The following is a description of a gene set: Reactions triggered in response to the presence of another organism that act to protect the cell or organism from damage caused by that organism. studied in species Mus musculus Mouse Gene Set: GOBP_DEFENSE_RESPONSE_TO_OTHER_ORGANISM, and this is the list of marker genes: Ccl19-ps3, Naip6, Tifa, Nr1d1, Cd226, Siglecg, Cxcl11, Vip, Wfdc13, Aqp1, Ccl17, Pfpl, Clpb, Aicda (activation-induced cytidine deaminase), Cfh, Klrg1, Ptprc, Klrb1 (killer cell lectin-like receptor subfamily B member 1), Npy, Atl3, Gbp8, Agbl5, Bnip3, Fv1, Neurl3, Tlr1, Usp50, Oas3, Cdc42, Batf, Defb40, C8g, Hmgb1, Lyzl6, Btk, Sprr2a1, Zdhhc1, Trim3, Il10rb, Nt5c2, Jak3, Ifnab, Fcer1g, Tarbp2, Gzmc, Zfp683, Lamp1, Epha2, Pik3cd, Samhd1 (NCBI Gene Id 56045), Epg5, Bpifa1, Rnf31 (ring finger protein 31), Defa25, Ap3b1, Rab1a, Cd207, Casp4, Wfdc2, Nop53, Sin3a, Ifi213, Serpinb1a, Myo1f, Calm3, Nek7, Gpatch3, Defb39, Casp1, Defb30, Irgm1, Slfn9, Il23a, Reg2, Tkfc, Arf6, Raet1e, F2, Lrrc15, Trim31, D1Pas1, Mptx2, Il12a, Adamts4, Tnfrsf14, Tgfb1, Ripk3, Tax1bp1, Cdc42ep2, Trim43a, Rab27a, Cst9, Ifitm3, Prkdc, Jak2, Arid5a, Ubd, Ifna7, Stx11, Traf3ip2, Defb35, Seh1l, Bpifa2, Fcna, Tmem106a, Crp, Ch25h, 9930111J21Rik1, Usp17le, Galp, Defa20, Il7r, Erbin, Trim11, Trim43c, Ass1, Trim55, Gfi1, Calhm6, Nmb (NCBI Gene Id 68039), Nlrp9c, Trex1, Defb46 (NCBI Gene Id 574081), Fbxo9, Fpr-rs4, Cxcl5, Hmgb2, Cd300e, Oasl1, Zdhhc12, Klre1, Rab7b (NCBI Gene Id 319567), Ear2, Slamf7, Wipi2, Fosl2, Pspc1, Myd88, Cd160, Clec4e, Apoe, Hamp2, Pglyrp2, Wfdc5, Hck, Ccl22, Foxp3, Rnf135, Rab12, Gapdhrt, Nfkb1, C1ra, Klrb1b, Ccl2, Defa40, Eif2ak4, Arhgef2, Cadm1, Il17f, Dus2, Nectin4, Fbxl2, Ifngr1, Trim30a, Znrf4, Il27, Tnip1, Lrrc19, Il1rl2, Defb42, Dmbt1, Gbp9, Ccl1, Defa35 (defensin, alpha, 35), Hras, Mmp3, Ncf1, Exosc4, Defa34, Akap8, Adm (adrenomedullin), Apobec3, Zbtb1, Trim60, Rnaset2b, Defa28, Snx3, Wdfy1, Rnf185, Chmp3, Ninj1, Cybc1 (NCBI Gene Id 217370), Il1rap, Prkra, Ppp6c, Pten, C1qbp, Mif, Raet1d, Tspan32, Pla2g6, Ifit1, Ccl19-ps4, Tlr12, Nlrp6, Ube2w, Reg1, Sting1, Clec4a4, Defa37, Hvcn1, Ppt1, Hpx, Defb50, Klk5, Mark4, Lep, Il21 (interleukin 21), Calm1, Unc93b1, Pglyrp4, Tlr2, Lyz1 (lysozyme 1), Rsad2, Gm13276, Syncrip, C1qc, C1rl, Ifna16, Ccdc88b (coiled-coil domain containing 88B), Itgax, H2-T23, Zdhhc5, Kcnk13, Il36g, Pld3, Lgals4, Trim65, Gsdma2 (NCBI Gene Id 78322), Ccl5, Slamf1, Prdx1, Ripk2, Itln1, Slamf6, Rb1cc1, Il4, Tnfaip8l2, Defb18, Ighm, Trim21, Cd74, Ceacam1, Pum1, Oas1b, Pqbp1, Wfdc9 (WAP four-disulfide core domain 9), Il17rc, Clec4n, C1qa, Gm12185, Spag11a, Masp2 (NCBI Gene Id 17175), Msrb1, Ifnb1, Ptpn2, Fpr-rs6, Tmem33, Irf2, Tnip3, Pvr, Ins2, Trim25, Il17a, Serpinb9f, Wfdc21, Atad3a, Cd300lf, Ccl6, Gm5849, Defb15, Polr3k, Phb2, Ifne, Smarca5, Defb10, Adam15, Trim39, Cr2, Plscr1, Ddx17, Shmt2, F830016B08Rik, Lats2, Myo1c, Emilin1, Slc15a3 (solute carrier family 15, member 3), Rnf115, Il18rap, Calcoco2, A2m, S100a14, Mov10, Ddx41, Lgals3, Apcs, Wnt5a, Ppl, Usp38, Trim34b, Nr1h3, Nlrx1, Plpp6, Plac8, Trim30b, Trim30d, Pmaip1, Pja2, Axl, Trem3, Pla2g10, Ifnlr1, Ccl12, Xrcc5, Defb8, Tnfsf8, C1qb, Trim7 (NCBI Gene Id 94089), Acp5 (acid phosphatase 5, tartrate resistant), Map4k2, Mmp7, Cd47, Ifi207, Syt11, Trem2, Drd2, Akap1, Dhx36, Sirpa, Daxx, Gbp5, Arl8b, Rab43, Fgr, Dtx3l, Arg2, Bpifa5 (NCBI Gene Id 72437), Gm13277, Cybb, Mfhas1, Gramd4, Klrh1, Itch, Defa2, Gm13275, Tmem120a, Pum2, Ifna5, Il36rn (NCBI Gene Id 98939), Armc5, Lta, Rpl13a, Shfl, Defa39, Defa26, Defb19, Casp8, Krt6a, Ly86, Lyar, Defb13, Nmi, Smim30, Ccl21d, Mapkapk2, Ighg2b, Ilrun, Ifitm6, Wfdc15a, Trim8, Nono, Nfkbiz (nuclear factor of kappa light polypeptide gene enhancer in B cells inhibitor, zeta), Cebpg, Pcbp2, Lalba, Rnaset2a, Serpine1, Was, Slc30a8, Cep63, C4b, Rnase12, Polr3c, Dnaja3, Ifi203-ps, Casp6, Kng2, Cfhr4, Klrc1, Tab2, Irak2, Gimap5, Rpsa, Ppm1b, Bspry, Lrrc14, Ppp2ca, Ifitm2, Oas1a, Ly96, Usp29, Mre11a, Nod2, Ffar2, Tlr4, Zmpste24, C9, Mpo, Vav1, Zmynd11, Defa17, Sqstm1, Banf1, Trem1, Oas1f, Gimap3, Dhx9, Rnasel, Ilf3, Emilin2, Dicer1, Krt1, Nlrc4, Hamp, Ifi208, Il22ra1, Letmd1, Chga, Ccl28, Gm15441, Rnase2a, Wfdc17, Esr1, Defa3 (defensin, alpha, 3), Cd244a, Nlrp4a, Mapkbp1, Ccl21b, Defb47 (NCBI Gene Id 654465), Colec11, Klk7, Stat5a, Zdhhc11, Rnf216, Gm13272, H2bc21, Fga, Vamp8, Trim50, Peli3, Reg3g, Defa38, Cldn1, Kcnj8, Srebf1, Ptpn6, Cd37, Serping1, Ppbp, Ulbp1, Irf7, Ifna11, Tlr6, Kif16b (kinesin family member 16B), Nfkbia, Fasl, Sp110, Rnf39, Ifi209, Vsig4, Aurkb, Gpr146, Slc26a6, Nlrp9b, U90926, Defa29, Smpdl3a, Foxp1, Elmod2, Ssc5d, Smpd1, Pla2g5, Klrd1, Traf3ip1, Ifit1bl2, Tgtp2, Klri1 (killer cell lectin-like receptor family I member 1), Sertad3 (SERTA domain containing 3), Vnn1, Ticam2, Defb3 (NCBI Gene Id 27358), Gch1, Sfn, Cav1, Sarm1, G3bp2, Ifna15, Nectin2, Gimap6, Prdm1, Defa24, Htra1, Camk2a, Ndufs4, Slfn8, Kat5, Atat1, Dhx58, Parp9, Ccl3, Hexim1, Defb43, Naglu, H2-M3, Ulbp3, Colec12 (NCBI Gene Id 225157), Irak1, Ipo7, Rnf26rt (NCBI Gene Id 669536), Plekhm2, Cd84, Il33, Gm12250, Slamf8, Defa30, Defb7, Sh2d1a, Ciita, Elp6, Aars2, Rftn1, Eprs1, Ear14, Ticam1, Znrf1, Rnf125, Gzmn, Fgl2, Ccl25, Il36a, Mx1, Il1b, Gzmb, Tnfaip8, Mr1, Muc19, Dpp4, Ccl7, Sh2d1b2, Marco, Ubqln1, Ang4, Ighe, Klrb1a, Klrb1c, Hp, Ywhaz, Cd36, Zdhhc4, Syk, Dcst1, Clnk, Lacc1, Ctsg, Ins1, Jagn1, Mbl2, Ncr1, Fpr-rs7, Trim30c, Defb21, Ifi35, Txk, Gm4841, Gata6, C3, Tmem45b, Ifit1bl1, Prkd1, Ppp1r14b (protein phosphatase 1, regulatory inhibitor subunit 14B), Klrc2 (killer cell lectin-like receptor subfamily C, member 2), Ccl26, Polr3g, Ang6, Csf1r, Trim61, Tyrobp, Fau, App, Sprr2a3, Fgb, Cd55b, Trim12a, Lrch4, Cd2, Trim72, Igha, Colec10, F2rl1 (NCBI Gene Id 14063), Gbp2, Ear1, Tnf, Cd55, Cxcl9, Phb1, Ifnk, Actg1, Defb33, Serpinb9c, Rasgrp1, Slc19a1, Fcgr1, Isg20, Marchf2, Morc3, Defb34, Mpeg1, Il6, Defb48 (defensin beta 48), Slamf9, Defb5, Tslp, Irak4, Kynu, Bpifb1, Rab2b, Trim40, C8b, Cxcl15 (C-X-C motif chemokine ligand 15), Il17ra, Ccr1, Ap1g1 (NCBI Gene Id 52301), Rps6kb1, Irf8 (NCBI Gene Id 15900), Wfdc15b, Ccl21e, Iigp1, Abcc1, Chid1, Cyp27b1, Rbm47, Traf4, Nlrp4b, Tollip, Tlr7, Rnf166, Krt16, Ly9, Cxcl16, Wap, Nagk, Cactin, Wfdc6a, Masp1, Ncbp1, Atg9a, Pf4, G3bp1, Ccdc134, Pde12, Trim14, Rnase4, Iigp1c, Ltf, Defb22, Src, Dao, Mx2, Il23r, Ifit3b, Sirt2, Ifna2, Fadd (NCBI Gene Id 14082), Mapk8, Ifi205, Il12rb1, Aif1, Trim15 (NCBI Gene Id 69097), Cebpb, Eif2ak2, Oas1g, Tirap, Pik3r1, Wrnip1, Nkg7, Cotl1, Klrb1f, Trim41, Defb20, Rtn4, Nlrc5, Dhx16, Gm13271, Ifnz, Nfkbil1, Ifi214, Muc5b, Cyba, Ccl9, Appl1, Chuk, Cfb, Zdhhc3, Hmgb3, Gm13283, H2-Q7, Dab2ip, Mill1, Reg3b, Cxcl1, Pglyrp3, Slc22a5, Wfdc16, Usp44, Pld4, Gapdhrt2, C8a, Clec4d, Mptx1, Bpifc (BPI fold containing family C), Stx4a, Pstpip1, Gigyf2, Mul1 (mitochondrial ubiquitin ligase activator of NFKB 1), Ncr3-ps, Cd14, Gsdmd, Tmf1, Otop1, Nlrp4f, Usp20, Stat1, Pml, Gapdh (NCBI Gene Id 407972), Cd300c2, Cd1d1, Ogt, Shc1, Ankrd17, Polr3e, Dusp10, Oas1e, Rad50, Nlrp3, Gm6040, Lypd8, Pim1, Usp14, Rela, Fcer2a, Oprk1, Defa42, Mmp12, Rigi, Ifitm7, Hyal2, Atg12, Rab14, Il4ra, Ddx21, Defb14, Cd96 (CD96 antigen), Rarres2, Rasgrp4, Star, Zg16, Cr1l, Cx3cr1, Gsdmc4, Usp15, Zbp1, Ythdf2, Polr3a (polymerase (RNA) III (DNA directed) polypeptide A), Defb1, Cd1d2, Hk1, Cxcl13, Bpi, Cxcl14, Inpp5d, Ubl7, Vps26b, Nppb, Edn1, Lag3, Trim62, Crtam, Clec4b2, Rnase10, Ufd1, Defb11, Brcc3dc, Xcl1, Zdhhc18, Cd177, Rbm14, Hrg, Ddx39a, Serinc5, Stxbp2, H60c, Bcl2, Polr3b, Spi1, Cx3cl1, Rbpj, Clec4a2, Enpp1, Adam8, Tusc2, Apoa4, Hspd1, Rnf144a, Gsn, Trf, Akt1, Becn1, Havcr2, Adamts5, Rnase1, Cyld, Nedd4, Nlrp1b, Il36b, Stx8, Serpinb9g, Wfdc3, Rpl30, Bcl10, C1s2, Slc46a2, Tlr3, Zcchc3, Endod1 (endonuclease domain containing 1), Fpr2, Ifnl2 (interferon lambda 2), Herc6, Rag2, Csf1, Fam3a, Trim12c, Trim10, Lyz2, Abcf3, Ccdc92, Ccl20, Trim56, Ccl24, Lyplal1, Abhd17a, Creb3, Ifi211, Bcl2l1, Ighg2c, Lrrfip2, Dapk1, C4bp, Ivl, Rnf34, Gbp6, Ifi203, Pdpk1, Brcc3, Trim54, Triml2, Tab1, Senp7, Gpr15lg, Sharpin, Camp, Ear10, Mmrn2, Stab2, Cstdc2, Gsdmc3, Rpl39, AY761185, Mid2, Lyn, Xiap, Mlkl, Cd300c, Gps2, Defa22, Oasl2, Wfdc11, Ptx3, Naip1, Ikbkg, Tspan6, Ighg1, Rnase13, Capg, Setd2, Apol11a, Trim34a, Nt5c3, Gpam, Reg3a, Ifna12, Cd4, Lyz3, Flicr, Vamp4, Usp18, Nras, Trim58, Tril (NCBI Gene Id 66873), Mettl3, Pla2g2a, Skp2, Ddx56, H60b, Actr2 (actin related protein 2), Cpt1a, Ang (angiogenin, ribonuclease, RNase A family, 5), Lyst, Sftpd (surfactant associated protein D, NCBI Gene Id 20390), Il10, Inava, Gsdma3, Ang2, Ighg3, Lrsam1, Tasl, Defb9, Matr3, C1s1, Appl2, Map3k5, Trim63, Trim35, Drosha, Garin5a, Wfdc18, Traf3ip3, Ube2n, Hdac4, Tbkbp1, Vim, Rel, Klrc3, Ifng, Eppin, Prkcd, Epx, Tnfsf4, Trim26, Nlrp4c, Tifab, Cfi, Rab11fip5, Ifnar1, Adamts13, Ttll12, Defa21, Traf6, Pgc, Prf1, S100a9, Defb41, Nlrp1a, Ppp1r11, Ifna1, Serpinb9d, Cd300a, Gpr108, Aqp4, Nr1h4, Ifit3, Ywhae, Tnfaip3 (NCBI Gene Id 21929), Cd274, Peli1, Leap2 (NCBI Gene Id 259301), Nod1, Sh2d1b1, Defb36, Bst2, Evpl, Cptp, Lcn10, Irf1, Lyg2, Uba7, Irf3, Gsdma, H2-K1, Lcn2, Akirin2, Fosl1 (NCBI Gene Id 14283), Padi4, Ifna9, Sp100, Cdc42ep4, Optn, Inhca, Atg5, Il34, Defb12, Rps6ka3, Rnase2b, Usp27x, Cgas, Clec12b, Rnf19b, Susd4, Cnot7, Rnf213, Scd1, Oas1d, Ttc4, Notch2, C5ar1, Bnip3l-ps, Cxadr, Slc9a9, Cxcl10, Tagap, Wfdc10, Casp7, Serpinb9, Slc22a21, Ifitm1, Eif4e2, Nlrc3, Lrp8, Defb25, Trim5, Ube2k, Ccl27al, Map3k7, Dhx33, Ifnar2, Rab20, Ecsit, Pcyox1l, Gper1, Adar, Rnase11, Nqo1, Myo18a, Cdc37, Tap1, Nck1, Cfp, Wfdc12, Defa41, Defb37, Hcfc2, Jchain, Irf4, Trim68, Ddit4, Nfe2l2, Ifngr2, Igtp, Mcoln2, Grn, Ereg, Tmem126a, Stxbp4, Ythdf3, Gbp7, Fcnb, Fgg, Hsp90aa1, Ankhd1, Sec14l1, Serpinb9b, Mefv, Anxa3, Ang5, Hspa8, Gbp2b, Calm2, Pla2g1b, Malt1, Ppp2r3c, H2bc12, Tlr11, C2, Ptprs, Tlr9, Mapkapk3, Cd40, Ifna13, Trim44, Clec4b1, Nrros, Mndal, Il31ra, Snca, Trim17, Pycard, Trim43b, Traf2, Slc15a4, Ercc6, Clec2d, Lyzl4 (NCBI Gene Id 69032), Defb2, Triml1, Ifi204, Adam17, Dhx15, Ifi206, Mrc1, Ndufaf4, Umod, Gm5431, Ddx3x, Jak1, Rab34, Atl2, Trim13, Spn, Defa5, Adgrb1, N4bp1, Plcg2, Irf5, Cd300ld3, Bpgm, Ddx1, Bnip3l (BCL2/adenovirus E1B interacting protein 3-like), Gapdh-ps15, Defb29, Crk, Cd209d, Lgals9, Kctd9, Tlr8, Polr3h, Gsdmc, Crcp, Lgr4, Rnf170, Cd24a, Anxa1, Prkce, Fcgr4, Nlrp10 (NLR family, pyrin domain containing 10), Arrb2, Batf2, Cxcl12, Slpi, Lbp, Apobec1, Vapb, Slc15a2, Prg2, Spsb3, Card9, Ifi27l2b, Tfeb, Slc11a1, Evl, Cst11, Igf2, Ifi44l, Sdhaf4, Cd86, Znfx1, Washc4, Lats1, Spon2, Ifnl3, Sfpq, Tgtp1, Hmgn2, Ifna6, Unc13d, Parp1, Zdhhc9, Trim38, Ccl19-ps6, Arg1, Trim52, Zfp809, Atg16l1, Zyx, Rnase6, Trim28, Nlrp9a, Relb, Cldn2, Pik3ap1, Nbn, Cfd, Scnn1b, Oas2, Atg7, Trim29, Tlr5, Abcc9, Ifna4, Gkn2, Zc3h12a, Hmgn2-ps, Nmbr, Treml4, Slk, Ccl11, Grb2, Actr3, Reg3d, Gbp3, Serinc3 (NCBI Gene Id 98830), Serpinb9e, Kng1, Il12b, Ear6, Acod1, Stab1, Unc13b, Ncbp3, Dtx4, Ppp1r14bl, Ccl21f, Romo1, P2rx7, Trim27, Tyro3, Naip2, Coro1a, Il18, Naip5, Fpr-rs3, Defb6, Zc3hav1, Ptgs2os, Xrcc6, Defb38, Ccl19, Clec5a, Tmem43, Dapk3, Smpdl3b, Flot1, Trim59, Nploc4, Lgals8 (lectin, galactose binding, soluble 8), Rps19, Trim75, Hc, Gbp4, Pik3r6, Bcl3, Tmeff1, Atg14, Tbk1, Tab3, Stat2, Otulin, Ccl21a, Oas1h, Flnb, Pomc, Ifit2, Aim2, Gp2, Lamp2, Uap1, Smurf1, Tap2, Klrk1, Mapk3, Gdi1 (NCBI Gene Id 14567), Isg15 (ISG15 ubiquitin-like modifier), Spag11b, C1rb, Alpk1, Vamp3, Tarm1, Lyg1, Tac1, Otud4, Exosc5, Epsti1, Defb4, Scimp, Ipo5, Clec4a1, Polr3f, Stmp1, Lpo, Ube2l6, Stat5b, B2m, Clec7a, Irak3, Mavs (mitochondrial antiviral signaling protein), Trp53, Slc30a1, Nos2, Cd180, Defa31, Tlr13, Ccl27b, Pik3cb, Pglyrp1, Oas1c, Defa23, Gfer, Il15, Pla2g2f, Cnpy3, Cited1, S100a8, Ifna14, Polr3d, Hcst (NCBI Gene Id 23900), Riok3, Gata3, Rnf26, Ccl27a, Mst1r, Mst1, Rfpl4, Mbl1, Lrrd1, Ikbke (inhibitor of kappaB kinase epsilon), Trim32, Gsdmc2, Rnase9, Pld1, Tnip2, Ptpn22, Tomm70a, Csnk1a1, Rbck1, Ly6e, Rtp4, Nts, Vgf, Map3k14, Il27ra, Irgm2, Tyk2, Ifi47, Mir511, Ccl19-ps5, Kif5b, N4bp3, Trim6, Gbp10, Ccl19-ps1, Cd8a, Klri2, Ddx60, Ccl8, Lsm14a, Agbl4, Ifih1, Serpinb9h, Clec4a3, Med1, Trafd1, Hspa1b, Rab11fip2, Stxbp3, Selenok, Nlrp4e, Stxbp1, Pparg, Parp14, Traf3, Elane, Tnfrsf1a, Trim69, Ccl4